Given this list of marker genes Dhfr, Mthfr (methylenetetrahydrofolate reductase), Gart, Mthfd1 (methylenetetrahydrofolate dehydrogenase (NADP+ dependent), methenyltetrahydrofolate cyclohydrolase, formyltetrahydrofolate synthase), Ftcd, Tyms, Gch1, Sardh, Mthfs, Mthfd2, Aasdhppt (aminoadipate-semialdehyde dehydrogenase-phosphopantetheinyl transferase), Dmgdh, Mthfd1l, Shmt2, Mthfd2l, Shmt1, Mtr, Aldh1l2, Slc46a1, Mthfsl, Atic, Folr1, Aldh1l1, here is a description of the gene set: species: Mus musculus The chemical reactions and pathways involving tetrahydrofolate, 5,6,7,8-tetrahydrofolic acid, a folate derivative bearing additional hydrogens on the pterin group. Mouse Gene Set: GOBP_TETRAHYDROFOLATE_METABOLIC_PROCESS